Given this list of marker genes ADAP1, ADAM17, ERBB4, WWOX, NCSTN, CXCL12, GFAP, S100B, NRG2, NCOR1, HBEGF, STAT5A, PSEN2, PGR, APH1A, MXD4, NRG3, ESR1, SRC, YAP1, NRG4, TAB2 (NCBI Gene Id 23118), NRG1, APOE, CSN2, PSENEN (presenilin enhancer, gamma-secretase subunit), APH1B, STMN1, PSEN1, SPARC, EREG, BTC, here is a description of the gene set: studied in species Homo sapiens Nuclear signaling by ERBB4 Human Gene Set: REACTOME_NUCLEAR_SIGNALING_BY_ERBB4